The following is a description of a gene set: Type I interferon to Jak-STAT signaling pathway. Pathway ID: N01558. Pathway type: Reference. Pathway class: nt06518 JAK-STAT signaling. Human Gene Set: KEGG_MEDICUS_REFERENCE_TYPE_I_INTERFERON_TO_JAK_STAT_SIGNALING_PATHWAY Pathway Definition from KEGG: (IFNA,IFNB1,IFNW1,IFNK,IFNE) -> (IFNAR1+IFNAR2) -> (JAK1+TYK2) -> (STAT1+STAT2) == IRF9 species: Homo sapiens, and this is the list of marker genes: JAK1, IFNA6, IFNK, IFNA21, STAT2, TYK2, IFNA7, IFNA5, IFNA16, IFNA8, IFNAR1, IRF9, IFNW1, IFNA10, STAT1, IFNA4, IFNE, IFNA17, IFNA1, IFNA13, IFNAR2, IFNA14, IFNB1, IFNA2